Given this list of marker genes CAMKV, PSME3 (NCBI Gene Id 10197), FAM53A, SOAT1, RNF44, CALR (NCBI Gene Id 811), TGFB3, HS1BP3, TRABD2B, CASKIN2, TENM3, EFNA3, ZNF512B, NFIX, TMEM119, NAA50, DMRTB1 (NCBI Gene Id 63948), BRD2, GIT1, DYNC1LI2, RNF121, GCN1, KMT2D, ZBTB47, BRD10, PCSK9, OTUD5, LHFPL1, ULK1, EPN3, USP6NL, KIF3A, SUN2, ENDOV, ZFP91, NR3C2, CASQ1, TRIM37, WSCD2, ARID3B, ZBTB41, A1CF, KLHL18, CELF5, TCP10L (NCBI Gene Id 55264), RIMS1, CDH3, KRAS, CHRNG, TMEM129, DGKQ, RORB, PTPRU, SRF, here is a description of the gene set: from publication Chen Y, Wang X (PMID 31504780) Genes predicted to be targets of miRBase v22 microRNA hsa-miR-4758-3p in miRDB v6.0 with MirTarget v4 prediction scores > 80 (high confidence targets). Human Gene Set: MIR4758_3P studied in species Homo sapiens